Given this list of marker genes Faf2, Trim21, Kif5b, Klc1, Dyrk3, Zfand1, Vcp, here is a description of the gene set: studied in species Mus musculus The disaggregation of a stress granule into its constituent protein and RNA parts. Mouse Gene Set: GOBP_STRESS_GRANULE_DISASSEMBLY